Given this list of marker genes Uckl1, Dguok, Ada, Pnp2, Aprt, Tymp, Tk1 (NCBI Gene Id 21877), Adk, Ampd2, Gmpr2, Ampd1, Ampd3 (adenosine monophosphate deaminase 3), Uck2, Gmpr, Tk2 (NCBI Gene Id 57813), Hprt1, Uck1, Dck, Pnp, Pudp, Upp1, Cda, Upp2, Adal, here is a description of the gene set: studied in species Mus musculus Nucleotide salvage Mouse Gene Set: REACTOME_NUCLEOTIDE_SALVAGE